The following is a description of a gene set: studied in species Mus musculus Mouse Gene Set: GOBP_POSITIVE_REGULATION_OF_INTERLEUKIN_10_PRODUCTION Any process that activates or increases the frequency, rate, or extent of interleukin-10 production., and this is the list of marker genes: Clec7a, Il6, Cd274, Hmgb1, Stat3, Cd83, Lilra5, Pycard, Cd28, F2rl1, Hgf, Il13, Trem2, Tlr2 (NCBI Gene Id 24088), Nod2, Ptger4, Lgals9, Prkcz, Irf4, Pibf1, Xcl1, Inava, Tnfsf4, Il20rb, Cd46, Tnfsf18, Isg15, Il21 (interleukin 21), Tusc2, Tslp, Tigit, Tlr9, Sash3, Cd40lg, Fcer1g, Plcg2, Il12b, Syk, Bcl3 (NCBI Gene Id 12051), Rbm47 (RNA binding motif protein 47), Il4, Tlr4, Rad21, Il23a, Hspd1